Given this list of marker genes GRB2, BEX3, NGF, FRS2, SHC1, BDNF, NTF4, EFNA5, PLCG1, PIK3R1, NTF3, NTRK1, here is a description of the gene set: Binding to a neurotrophin receptor. Human Gene Set: GOMF_NEUROTROPHIN_RECEPTOR_BINDING species: Homo sapiens